The following is a description of a gene set: species: Homo sapiens Human Gene Set: HP_SEVERE_INTRAUTERINE_GROWTH_RETARDATION Severe intrauterine growth retardation Intrauterine growth retardation that is 4 or more standard deviations below average, corrected for sex and gestational age., and this is the list of marker genes: ESCO2, GRB10, NIN, IGF2, PTF1A, EMG1, H19, ERI1, TBCE, POLR3A, IGF1, RECQL4, UBR1, INSR, CEP57